The following is a description of a gene set: from publication Dittmer A, Vetter M, Schunke D, Span PN, Sweep F, Thomssen C, Dittmer J (PMID 16551631) Genes down-regulated in MDA-MB-231 cells (breast cancer) after knockdown of PTHLH by RNAi. Human Gene Set: DITTMER_PTHLH_TARGETS_DN The effect of endogenous parathyroid hormone-related protein (PTHrP) on gene expression in breast cancer cells was studied. We suppressed PTHrP expression in MDA-MB-231 cells by RNA interference and analyzed changes in gene expression by microarray analysis. More than genes showed altered expression in response to a PTHrP-specific small interfering (si) RNA (siPTHrP). Cell cycle-regulating gene CDC2 and genes (CDC25B and Tome-1) that control CDC2 activity showed increased expression in the presence of siPTHrP. CDC2 activity was also found to be higher in siPTHrP-treated cells. Studies with PTHrP peptides 1-34 and 67-86, forskolin, and a PTH1 receptor (PTH1R)-specific siRNA showed that PTHrP regulates CDC2 and CDC25B, at least in part, via PTH1R in a cAMP-independent manner. Other siPTHrP-responsive genes included integrin alpha6 (ITGA6), KISS-1, and PAI-1. When combined, siRNAs against ITGA6, PAI-1, and KISS-1 could mimic the negative effect of siPTHrP on migration, whereas siKISS-1 and siPTHrP similarly reduced the proliferative activity of the cells. Comparative expression analyses with 50 primary breast carcinomas revealed that the RNA level of ITGA6 correlates with that of PTHrP, and higher CDC2 and CDC25B values are found at low PTHrP expression. Our data suggest that PTHrP has a profound effect on gene expression in breast cancer cells and, as a consequence, contributes to the regulation of important cellular activities, such as migration and proliferation. species: Homo sapiens, and this is the list of marker genes: MINK1, LMNA, MT1G, NDUFB3, KDELR2, RPP30, TBC1D1, BCKDHA, SFXN3, MRPS14, DFFA, KIF3B, FAT1, SERPINE1, TCP1, MT1X, YME1L1, PANX1, RRAS2, CREB1, FBXO7, ITGA6, SEC24A, IVNS1ABP, ZDHHC7, MAPK6, ADAMTS1, GLS, AOX1, PIK3CA, MYH9, POLD2, BTNL3, PIK3R1, SERPINA4, HSP90AA1, UBAP2, TIMELESS, MMS19, FERMT2 (FERM domain containing kindlin 2), LRBA, EIF4G1, RAPGEF2, ARPC2, PDHB, MT2A, LRRFIP1, NDUFS4, SPTLC2, KISS1, MCAM, ACTG1, CASP1, MT1H, SPEN, FAH, SEMA3A, MRPL34 (mitochondrial ribosomal protein L34), TFDP2, PSMB4, SNX13, TOMM70, SLC22A14, PTK2, SP110, RGS10, ALDH7A1, HSPA2, MAP3K7, CUL4A